Given this list of marker genes KIF17, C19orf47, SERPINH1, LMF2 (NCBI Gene Id 91289, lipase maturation factor 2), PRX, ANKRD46, POM121L12, CHMP5, YY1AP1, FAM53A, C1orf35, CLDN19, CSF1, SRF, MYO1C, KCNC1, SMPD3, DMTN, SIGLEC5, FAT2, CDHR3, TMPRSS4, TGFA, PPM1G, LIMD1, WDR5B (WD repeat domain 5B), RYBP, TSPAN9, KIF3C, PHACTR2, PHF8, MAVS, PRDM16, TROAP, MAPKAPK2, LARP1, SLC25A22, ZFAT, YKT6, TREM1, ARHGAP19, MGLL, USF2, ZDHHC3, NACC2, DAGLA, CALHM1, LINC00390, C12orf43, AGFG2, ATXN7L3, RASA4B, KIRREL1, NCAN, FAM193A, GALNS, COQ6, MYRF (NCBI Gene Id 84755), SLC6A19, SLC8A3, PKNOX1, PALM2AKAP2, RELT, CAMK4, SLC6A17, HAP1 (NCBI Gene Id 9001), SEMA4B, TMUB2, MTCL2, SLC31A1, GPSM3, MDGA1, CSRNP1, FCHSD1, MICALL1, ATG7, WNT4, LINC02953, STRN (striatin), H6PD, HAS2, TCF20, STK35, BBLN, DIRAS1, DERL3, SLC7A8 (NCBI Gene Id 23428), TRAF3, TBC1D13, AGAP1 (ArfGAP with GTPase domain, ankyrin repeat and PH domain 1), NECTIN1, TEC, LMX1B, AMT, ASTN1, NGB, SCNN1A, ELN, VGLL2, PELI3, SLC4A8, THRB, ETV3L, RGS5, SH3PXD2A, ITM2C, RAVER1, ARNT2, LHX6, ZFP41, CD276, ABCG4, MECP2, MAFK, ADGRE1, TUBA8, SPNS2, WDR5, PRRC1, GPR180 (NCBI Gene Id 160897), ADAMTS4, RIMS4, TRIOBP, ZFYVE28, NPTXR, DBNDD1, MAPK8IP3, CAPN5, TGM2, FLT4, SYNDIG1L, ELFN2, ASIC2, PSMF1, ANKS1A, CYP26B1, HIPK1, TLN1, STX1A, KMT2A, SSR1, VEPH1, STX1B, SIDT2, RNF5, VAMP1, MTUS2 (microtubule associated scaffold protein 2), GSPT2 (NCBI Gene Id 83029), RAB43, NPLOC4, SPRY4, RTN3, SORL1, FMOD, TNRC6B, ATP6V0A1, KIF21B, CDH24, ETV3, KIR2DL3, SHISA6, BCL2L13, PACS2, NDEL1, LCE5A, PITPNM2, LASP1, NAT8L, GATAD2B, ZNF622, IGF2, EHD2, EPHA10, ZDHHC18, VMP1, CBX6, DCHS1, ZNF112, DPEP2NB, EFNB3, CACNA1C, TGM6, BICRAL, ZNF609, SPTBN1, P2RY2, NGEF, PDPK1, UCK2, ACP7, LRTM2, APH1A, CADM3, VAV2, MEGF6, TXLNA, SPRN, FKBP11, PHYHIP, KCNJ6, ERAL1, CCDC177 (coiled-coil domain containing 177), CALN1, INA, PLEKHG5, GRM4, KLF13, CNGB1, RBM14-RBM4, HRH3, VPS72, FNTB, RAB2A, HMGA1, TMEM201, CELSR2, TRIAP1, CASTOR2, C10orf90, PPP1R9B, ACRBP, NCSTN, SORCS2, CAMK2A, TMEM86A, PEA15, SMYD5, TRPC5, SMARCD1, EEIG1, RBM4, CDK16, PLPPR2, PPP1R16B, SRRM4, RASL10B, NATD1, PACSIN1, GLCE, VPS53, MLC1, ANKRD52, PIK3R2, CNBD2, C14orf28, DMRTA2, UBE2QL1, THRAP3, HAAO, SHB, WNK2, LZTS3, DOCK3, UNC119B, STEAP3, TMEM63B, GSPT1, SCN2B, CALM3, HID1, CPLX2, CHGA, KLK6, SLC6A9, KRT16, CASP7, TOMM7, WDTC1, TMCC3, DCAF7, MAX, PAX4, SEPTIN9, PDE2A, SRPRA, SCN8A, TXNDC5, NFIC, MAF1, GDF15, TMCC2, PRR14L, CNNM4, GNAO1, ARF3, NAPG, GPR179, CLEC4E (C-type lectin domain family 4 member E), KSR1, VANGL1, NAA60, FOSL2, ZMAT2, C1QTNF6, DIP2C, MLXIP, RASA4, GPR108, SOX13, HEG1, ERGIC1, RAB3B, KRT6B, SORT1, AAK1 (AP2 associated kinase 1), SRSF3, BAALC (BAALC binder of MAP3K1 and KLF4), KRT9, DOT1L, GFER, PARP3, PDE6G (NCBI Gene Id 5148), SLC26A6, DDX60L, CNOT2, CAMKK1, HLA-DMA, COL27A1, MARK2 (microtubule affinity regulating kinase 2), NFASC, TTYH3, CPSF4, LINGO1, PKD1L2, LRRC27, RAB1B, NDUFA4L2, ZNF512B, CBFA2T3, PPFIA3, ZER1, SCN4B, CHMP1A, CRHR1, RASSF5, MAP3K14, NALF2, TRIM62, FBXO41, IKZF3, here is a description of the gene set: Genes predicted to be targets of miRBase v22 microRNA hsa-miR-6721-5p in miRDB v6.0 with MirTarget v4 prediction scores > 80 (high confidence targets). from publication Chen Y, Wang X (PMID 31504780) species: Homo sapiens Human Gene Set: MIR6721_5P